The following is a description of a gene set: species: Homo sapiens The adhesion of one lymphocyte to one or more other lymphocytes via adhesion molecules. Human Gene Set: GOBP_LYMPHOCYTE_AGGREGATION, and this is the list of marker genes: STK10, MSN, RAC2, ZAP70, JAM2